Given this list of marker genes MYCBPAP, GPRC6A, LINC02389, TUBBP5, HSD3B2, RXYLT1, SLC26A4, SNX25P1, IL1A, KDM4A-AS1, ULK4P1, BRWD1-IT1, VMO1, USP51, SNORA14A, EXOC3-AS1, NFIA-AS2, GTF2H2B, CBR1-AS1, LINC00887, VAV3-AS1, TYMSOS, KIRREL1-IT1, ZNF296, LINC02745, ZC3H12A, PNMA6F, TNFRSF10C, RNVU1-32, CAV3, ELAC1, MRGBP, BTBD3-AS1, PHB1P19, MAPK10-AS1, TEX41, CFAP47, CADM1-AS1, F2RL1, FRMPD3-AS1, BAK1, AMIGO1, ZNF683, ZNF786, ZNF845, HMBOX1-IT1, LINC00616, CTF1, LINC01837, HOGA1, SAXO1, LINC03021, RPL38P1, ZNF747, ATP2A1, RN7SL749P, PBDC1, LYG1, LY6E-DT, GALNT9, CLXN, GTF2IP13, LINC00923, MYADM-AS1, LMNB1-DT, VPS9D1-AS1, SLC22A1, ZNF597, NPHP4, LINC02718, UICLM, TTLL9, ANO7L1, AMD1P3, HDHD5-AS1, CCT6B, SPINK8, RNU6-518P, LINC02296, LINC02410, MINAR2, NOMO2, PTPN23-DT, MTERF2, PRICKLE2-AS1, LINC03122, ENSG00000235834, CASC8, here is a description of the gene set: Marker genes curated from the annotated cluster as represented in the Descartes Human Gene Expression During Development database. from publication Cao J, O'Day DR, Pliner HA, Kingsley PD, Deng M, Daza RM, Zager MA, Aldinger KA, Blecher-Gonen R, Zhang F, Spielmann M, Palis J, Doherty D, Steemers FJ, Glass IA, Trapnell C, Shendure J (PMID 33184181) The gene expression program underlying the specification of human cell types is of fundamental interest. The study authors generated human cell atlases of gene expression and chromatin accessibility in fetal tissues. For gene expression, the study authors applied three-level combinatorial indexing to >110 samples representing 15 organs, ultimately profiling ~4 million single cells. The study authors leveraged the literature and other atlases to identify and annotate hundreds of cell types and subtypes, both within and across tissues. Our analyses focused on organ-specific specializations of broadly distributed cell types (such as blood, endothelial, and epithelial), sites of fetal erythropoiesis (which notably included the adrenal gland), and integration with mouse developmental atlases (such as conserved specification of blood cells). These data represent a rich resource for the exploration of in vivo human gene expression in diverse tissues and cell types. studied in species Homo sapiens Human Gene Set: DESCARTES_FETAL_ADRENAL_SLC26A4_PAEP_POSITIVE_CELLS